The following is a description of a gene set: Genes up-regulated in peripheral blood mononuclear cell 2d vs 0d in adult (18-55) after exposure to Modified Vaccinia Ankara (MVA) virus vaccine vector, time point 2D A better understanding of the relationships between vaccine, immunogenicity and protection from disease would greatly facilitate vaccine development. Modified vaccinia virus Ankara expressing antigen 85A (MVA85A) is a novel tuberculosis vaccine candidate designed to enhance responses induced by BCG. Antigen-specific interferon-gamma (IFN-gamma) production is greatly enhanced by MVA85A, however the variability between healthy individuals is extensive. In this study we have sought to characterize the early changes in gene expression in humans following vaccination with MVA85A and relate these to long-term immunogenicity. Two days post-vaccination, MVA85A induces a strong interferon and inflammatory response. Separating volunteers into high and low responders on the basis of T cell responses to 85A peptides measured during the trial, an expansion of circulating CD4+ CD25+ Foxp3+ cells is seen in low but not high responders. Additionally, high levels of Toll-like Receptor (TLR) 1 on day of vaccination are associated with an increased response to antigen 85A. In a classification model, combined expression levels of TLR1, TICAM2 and CD14 on day of vaccination and CTLA4 and IL2Ralpha two days post-vaccination can classify high and low responders with over 80% accuracy. Furthermore, administering MVA85A in mice with anti-TLR2 antibodies may abrogate high responses, and neutralising antibodies to TLRs 1, 2 or 6 or HMGB1 decrease CXCL2 production during in vitro stimulation with MVA85A. HMGB1 is released into the supernatant following atimulation with MVA85A and we propose this signal may be the trigger activating the TLR pathway. This study suggests an important role for an endogenous ligand in innate sensing of MVA and demonstrates the importance of pattern recognition receptors and regulatory T cell responses in determining the magnitude of the antigen specific immune response to vaccination with MVA85A in humans. Human Gene Set: MATSUMIYA_PBMC_MODIFIED_VACCINIA_ANKARA_VACCINE_AGE_18_55YO_2DY_UP studied in species Homo sapiens from publication Matsumiya M, Stylianou E, Griffiths K, Lang Z, Meyer J, Harris SA, Rowland R, Minassian AM, Pathan AA, Fletcher H, McShane H (PMID 23844129), and this is the list of marker genes: SERPING1, IFIT1, S100A8, TICAM2, TLR6, IFI35, IFI6, TNFSF10, RSAD2, IL1A, CASP1 (caspase 1), IFITM2 (NCBI Gene Id 10581), BID, SLC15A3, ICAM1, BCL2A1, EIF2AK2, C3AR1, PILRA, APOBEC3A, TNF, IFI44L, IL6, DNASE2, DRAM1, STAT1 (signal transducer and activator of transcription 1), CCL2, ISG15, FCGR1A, CXCL10, XAF1, MX1, FPR3, IFI27, CCL4, RNASE2, PARP9, MARCO, CCL7, CFD, CARD16, S100A9 (NCBI Gene Id 6280), IFITM3, CCL3, BST2, IFIH1, CD68, CCL8, CTSL, TLR8, IFIT3, IRF9, PSMB9, SRC, GLMP, FPR2, FCGR1BP (Fc gamma receptor Ib, pseudogene), IL4I1, IFI44, ACP2, TYMP, TLR1, IFIT2, LGALS9, PYCARD (NCBI Gene Id 29108)